The following is a description of a gene set: species: Homo sapiens part of: Neurodegenerative Diseases Post-mitotic neurons do not have an active cell cycle. However, deregulation of Cyclin Dependent Kinase-5 (CDK5) activity in these neurons can aberrantly activate various components of cell cycle leading to neuronal death. Random activation of cell cycle proteins has been shown to play a key role in the pathogenesis of several neurodegenerative disorders. CDK5 is not activated by the canonical cyclins, but binds to its own specific partners, CDK5R1 and CDK5R2 (aka p35 and p39, respectively). Expression of p35 is nearly ubiquitous, whereas p39 is largely expressed in the central nervous system. A variety of neurotoxic insults such as beta-amyloid (A-beta), ischemia, excitotoxicity and oxidative stress disrupt the intracellular calcium homeostasis in neurons, thereby leading to the activation of calpain, which cleaves p35 into p25 and p10. p25 has a six-fold longer half-life compared to p35 and lacks the membrane anchoring signal, which results in its constitutive activation and mislocalization of the CDK5:p25 complex to the cytoplasm and the nucleus. There, CDK5:p25 is able to access and phosphorylate a variety of atypical targets, triggering a cascade of neurotoxic pathways that culminate in neuronal death. One such neurotoxic pathway involves CDK5-mediated random activation of cell cycle proteins which culminate in neuronal death. Exposure of primary cortical neurons to oligomeric beta-amyloid (1-42) hyper-activates CDK5 due to p25 formation, which in turn phosphorylates CDC25A, CDC25B and CDC25C. CDK5 phosphorylates CDC25A at S40, S116 and S261; CDC25B at S50, T69, S160, S321 and S470; and CDC25C at T48, T67, S122, T130, S168 and S214. CDK5-mediated phosphorylation of CDC25A, CDC25B and CDC25C not only increases their phosphatase activities but also facilitates their release from 14-3-3 inhibitory binding. CDC25A, CDC25B and CDC25C in turn activate CDK1, CDK2 and CDK4 kinases causing neuronal death. Consistent with this mechanism, higher CDC25A, CDC25B and CDC25C activities were observed in human Alzheimer's disease (AD) clinical samples, as compared to age-matched controls. Inhibition of CDC25 isoforms confers neuroprotection to beta-amyloid toxicity, which underscores the contribution of this pathway to AD pathogenesis Reactome Pathway: Deregulated CDK5 triggers multiple neurodegenerative pathways in Alzheimer's disease models, and this is the list of marker genes: CAST, CAPNS1, YWHAE, GOLGA2, PRDX2, BCL2L11, CDC25B, FOXO3, CDK5R1, SOD2, JUN (NCBI Gene Id 3725), LMNA, CAPN1, APP, CDK5, LMNB1, CDC25C, CAPN2, PRDX1, FASLG, CDC25A, CAPNS2